The following is a description of a gene set: studied in species Homo sapiens from publication Vitali C, Mingozzi F, Broggi A, Barresi S, Zolezzi F, Bayry J, Raimondi G, Zanoni I, Granucci F (PMID 22760781) Human Gene Set: GSE39022_LN_VS_SPLEEN_DC_DN Spleen and lymph node dendritic cells have a differential capacity do induce and retain iTreg cells. Therefore we performed a comparative analysis of the dendritic cells derived from these two compartments to identify the responsible genes Genes down-regulated in dendritic cells from: lymph node versus spleen., and this is the list of marker genes: RNMT, VEZF1, NDRG3, PUS1, ARHGEF7, SMG1, NXPE3, ERBB3, IFNAR1, KMT2C, KMT2E, TRIM59, XRCC5, MAPK14, FTL, MORC2, ACVR2A, ALDH2, MAP1S, RASGEF1C, HMG20A, STX1A, FBXO31, ZNF281, SLC17A9, PARN, KIDINS220, THADA, TBC1D1, GPD1L, PCED1B, CPSF1, ADO, LUC7L3, CPM, ARRB1, EARS2, SNX13, RABGAP1L, CD84, LDB1, HEATR3, RPUSD4, WDR91, C8orf82, TEC, USP27X, KLHL9, SNX4, HLCS, UTRN (NCBI Gene Id 7402), MTFR1L, NINJ1, RAD51D, PHTF2, ESYT2, ARID1B, GALNT11, ATP23, WIPF2, RSL24D1, NSFL1C, GCLM, SARAF, RGN, ZNF566, MAP6, MDN1, MOB3B, CDIPT, NOLC1, TOP2B, SMC4, ZNF438, C2orf68, SKP1, SNORD89, MRPL23, LAG3, LRRC42 (NCBI Gene Id 115353), C19orf12, PDSS2, DANCR, ECHDC1 (NCBI Gene Id 55862), SCCPDH, CABCOCO1, PATZ1, HSDL1, RPL13, BDH1 (3-hydroxybutyrate dehydrogenase 1), NOL12, RREB1, PNPLA7, BCLAF1, NOL8, DGKA, LTV1, ZNRD2, NKRF, RETREG1, CTPS2, ZNF608 (zinc finger protein 608), KLF13, PITRM1, RIDA, RAF1, BAHD1, UTP25, LYSMD2, MIGA1, SLC9B2, ZNF764, ZMYM2, ZBED5, C1QBP, TRMT10B, NFE2L2, RNF216, RHOH, IL9R (NCBI Gene Id 3581), RBMX, IGFBP4, KRTCAP3, CD3D, MRPS6, IQCB1, DGKQ, CITED2, CCAR1, S100PBP, CDS2, CTBP2, DSTYK, BAG3, DCAF1, NSUN5, NOP10, GPATCH4, NPEPPS, PIGP, POLR1E, HIVEP2, TDRP, OSGIN1, HEATR1, FAM120C, SERTAD2, PRNP, WDR6, MXD4, MTLN, JARID2, SLFN12L, TPD52L2, SHISA5, MCCC1, BFAR, D2HGDH, ADAMTSL4, GLB1, EHD3, GNL1, COQ9, NISCH, CD247, FAM118A (NCBI Gene Id 55007), DDX19B, CCR6, XPO4, JMJD8, CCDC24, CEPT1, SERPINB1, SLC7A1, ALKBH1, ANKRD44, TANC2, ELOVL5, MCEE, RPL22L1, MCRIP2, NOP56, BMPR2, CAMK1D, USP6NL, NARS2, SOCS2, MBP, IL10RA, IGF2R, GLRX5, TUFM, TXNRD3, IZUMO4, LIMS4, CCDC86 (NCBI Gene Id 79080), MAGED2, INTS13